Given this list of marker genes SOS1, IRS1, HRAS, KRAS, NRAS, IRS2, GRB2, here is a description of the gene set: species: Homo sapiens part of: IRS-mediated signalling Reactome Pathway: SOS-mediated signalling SOS is recruited to the plasma membrane and mediates activation of Ras.